Given this list of marker genes HMGB1, CENPE, MCM6, CSTF1, TOP2A (NCBI Gene Id 7153), BUB3, H2BC21, TP53, PRKDC, H2AX, H3C4, H2AC18 (H2A clustered histone 18), FEN1, RFC2, RPA3, DUT, MSH2, CDK2, CCNA2, RFC4, HMGB3, BARD1, SMC4, H2AC6 (H2A clustered histone 6), CHEK1, UMPS, CENPA, PTTG1, PRIM2, MCM3, E2F2, CKS1BP7, MLH1, RFC3, TK1, CDK1, RB1, POLD1 (DNA polymerase delta 1, catalytic subunit), CDC25A, RBL1, RAD54L, H2AZ1, SUPT4H1, PCNA, TTK, POLA2, UNG, SMC2, RAD51, BRD2, CDC6, ORC1, HLTF, MAD2L1, NAP1L4, NDC80, RRM1, POLA1, CBX5, E2F3, MCM5 (minichromosome maintenance complex component 5), DBF4, here is a description of the gene set: from publication Ren B, Cam H, Takahashi Y, Volkert T, Terragni J, Young RA, Dynlacht BD (PMID 11799067) The E2F transcription factor family is known to play a key role in the timely expression of genes required for cell cycle progression and proliferation, but only a few E2F target genes have been identified. We explored the possibility that E2F regulators play a broader role by identifying additional genes bound by E2F in living human cells. A protocol was developed to identify genomic binding sites for DNA-binding factors in mammalian cells that combines immunoprecipitation of cross-linked protein-DNA complexes with DNA microarray analysis. Among approximately genes expressed during cell cycle entry, we found that the promoters of 127 were bound by the E2F4 transcription factor in primary fibroblasts. A subset of these targets was also bound by E2F1. Most previously identified target genes known to have roles in DNA replication and cell cycle control and represented on the microarray were confirmed by this analysis. We also identified a remarkable cadre of genes with no previous connection to E2F regulation, including genes that encode components of the DNA damage checkpoint and repair pathways, as well as factors involved in chromatin assembly/condensation, chromosome segregation, and the mitotic spindle checkpoint. Our data indicate that E2F directly links cell cycle progression with the coordinate regulation of genes essential for both the synthesis of DNA as well as its surveillance. species: Homo sapiens Genes whose promoters were bound by E2F1 and E2F4 in the primary fibroblasts WI-38, by ChIP on chip assay. Human Gene Set: REN_BOUND_BY_E2F